The following is a description of a gene set: In the present study we used Affymetrix oligonucleotide microarrays to produce gene transcription profiles for the major leukocyte types in humans. This comprehensive dataset enabled us to not only establish which genes were expressed in each leukocyte type, but also which genes were expressed in each subset after activation. The used of a comprehensive dataset of gene profiles from all the major human leukocyte subsets enabled a novel and powerful means for identification of genes associated with single leukocyte subsets, or different immune paradigms. Human Gene Set: GSE3982_MAST_CELL_VS_CENT_MEMORY_CD4_TCELL_DN species: Homo sapiens Genes down-regulated in comparison of mast cells versus central memory CD4 T cells. from publication Jeffrey KL, Brummer T, Rolph MS, Liu SM, Callejas NA, Grumont RJ, Gillieron C, Mackay F, Grey S, Camps M, Rommel C, Gerondakis SD, Mackay CR (PMID 16474395), and this is the list of marker genes: IFT88, PHOX2A, SBF1, ZNF264, PSD3, ATP1A1, HRH3, SPOUT1, DPF1, CDR2, RAD9A, EPCAM, IL23A, TLE2, SCN3A, GPC3, AKR1C1 (NCBI Gene Id 9418), CYB561, PKD1P6, IFI44L, DEF6, GSTM2, SYNM, ANKRD36B, SLC10A2, BBS1, MPPE1, ARHGAP24, ZCWPW1, SF3B1, USP25, P2RY10, GARRE1, CHKB, CLEC2D, SUPT7L, PIM2, RPL4, ARL4C, EGFR, TAF5, GALNS, SREK1IP1, TCF7, ACHE, CD4, EVI2B, RPP25, PCNX2, ZC3HAV1, MAL, RSRP1 (NCBI Gene Id 57040), ANKRD2, CLK4 (NCBI Gene Id 57396), TPR, GLRA3, NECTIN3, LIMD2, TGS1, OBP2A, QSER1, GFOD3P, IRAK4 (interleukin 1 receptor associated kinase 4), UCP1, SH2D1A, JAK1, C1orf115, RAD54B, SLC7A6, ANKRD11, MBL2, SGPL1, CCND3, LTB4R2, HOOK1, CMTR1, CASK, PALM, KLHL22, ZNF493, USP13, SEPTIN9, MACF1, SARS2, DIDO1, IMPG1, ERF, RAPGEF6, ITK, ADD3, CD8B, ITGAL, FHL1, UBIAD1, HNRNPA1, C1S, PGGHG, SEPTIN7P11, CD28 (CD28 molecule), FCHSD2, SATB1, RFPL3S, MUC2, DDX51, DLG3, TREX1, ANKRD55, PRKY, PCID2, RPS13, RHOH (NCBI Gene Id 399), BOK, IFNG, ELOVL4, CYP27B1, EIPR1, GINS4, OXLD1, METTL4, PTPN2, ARFGAP1, POLG, DUSP2, RPS4X, CLDN16, SFI1, BBOF1, CLUAP1, EIF2B5, ERC2-IT1, OR1A1, CHTOP, GIMAP6, ARMCX2, PYY2, SH3BGR, USP20, STK17B, MCMBP, AP1AR, GIP, UIMC1, EVC (NCBI Gene Id 7886), TAFAZZIN, EZH1, MROH9, RAB35, WAPL, KIR2DL2, PNRC1, TSPAN32, CSPG4, PTPN4 (protein tyrosine phosphatase non-receptor type 4), SURF2, GMEB2, CAMTA1, ACVR2A, EIF1, RRAS2, SP3P, ADAM8, SCGN, MED25, PLEKHG3, LMBR1L, MREG, ZNF292, SIVA1, FRMPD1, ARHGAP5, TM4SF1 (transmembrane 4 L six family member 1), TMSB10, MTMR1, SOD3, IL11, H2AJ, TXK, TRAF3IP3, INPP4B, MBP, KLF2, RUFY3, ORC6, ZNF665, RPL5, NRXN1, KIF2A, LYPLA2, PTCD2, HLA-B, RAB40C, IRF7, SLC25A28, KIF1B, HLA-J (major histocompatibility complex, class I, J (pseudogene)), PXMP4, SORBS3, TMEM204